The following is a description of a gene set: from publication Cui A, Huang T, Li S, Ma A, Pérez JL, Sander C, Keskin DB, Wu CJ, Fraenkel E, Hacohen N (PMID 38057668) studied in species Mus musculus Mouse Gene Set: CUI_B_CELL_IL1A_RESPONSE_DN Cytokines mediate cell-cell communication in the immune system and represent important therapeutic targets. A myriad of studies have highlighted their central role in immune function, yet we lack a global view of the cellular responses of each immune cell type to each cytokine. To address this gap, the authors created the Immune Dictionary, a compendium of single-cell transcriptomic profiles of more than 17 immune cell types in response to each of 86 cytokines (>1,400 cytokine-cell type combinations) in mouse lymph nodes in vivo. A cytokine-centric view of the dictionary revealed that most cytokines induce highly cell-type-specific responses. For example, the inflammatory cytokine interleukin-1β induces distinct gene programmes in almost every cell type. A cell-type-centric view of the dictionary identified more than 66 cytokine-driven cellular polarization states across immune cell types, including previously uncharacterized states such as an interleukin-18-induced polyfunctional natural killer cell state. Genes negatively differentially expressed in cell type: B cell upon treatment with cytokine: IL-1α in mouse lymph nodes in vivo., and this is the list of marker genes: Fth1, Klf2, Cd52, Cd55, Igkc, Txndc5, Iglc2, Fosb, Coro1a, Ccr7, Fcer2a, Ets1, Iglc3, Foxp1, Limd2, Ighm, Hspa1b, S100a10, Ltb, Klf3, Jun, Rasgrp2, Rhob, Lsp1, Arhgap17, H1f2, H3f3a, Emp3, Hexb, Cd79b, Ier5, Swap70, Vim